The following is a description of a gene set: species: Homo sapiens An assembly of four or five subunits which form a structure with an extracellular N-terminus and a large loop that together form the ligand binding domain. The C-terminus is intracellular. The ionotropic glutamate receptor complex itself acts as a ligand gated ion channel; on binding glutamate, charged ions pass through a channel in the center of the receptor complex. The AMPA receptors mediate fast synaptic transmission in the CNS and are composed of subunits GluR1-4, products from separate genes. These subunits have an extracellular N-terminus and an intracellular C-terminus. Human Gene Set: GOCC_AMPA_GLUTAMATE_RECEPTOR_COMPLEX, and this is the list of marker genes: SHISA9, NRN1, ABHD12, SHISA8, CNIH2, GRIA4, DLG4, CACNG4, GRIA3, PORCN (porcupine O-acyltransferase), DLG3, CACNG5, CACNG7, CNIH3, ABHD6, GRIA2, GRIA1, SHISA6 (shisa family member 6), CPT1C, VWC2L, SACM1L, CACNG2, OLFM3, OLFM2, VWC2, SHISA7, GRID2, CACNG3, CACNG8 (calcium voltage-gated channel auxiliary subunit gamma 8), GRID1